The following is a description of a gene set: Human Gene Set: WP_LTF_DANGER_SIGNAL_RESPONSE_PATHWAY LTF danger signal response pathway studied in species Homo sapiens, and this is the list of marker genes: IRAK1, IFNB1, MYD88 (MYD88 innate immune signal transduction adaptor), TREM1 (NCBI Gene Id 54210), NFKB1, TNF, IFNA1, IRAK4, TLR4, MAPK1, CD14, IL1A, CXCL8, TLR2, IL1B, AGER, LTF, IL6, TRAF6